The following is a description of a gene set: Human Gene Set: GSE11057_NAIVE_VS_CENT_MEMORY_CD4_TCELL_UP Genes up-regulated in comparison of naive T cells versus central memory T cells. Microarray deconvolution is a technique for quantifying the relative abundance of constituent cells in a mixture based on that mixture's microarray signature and the signatures of the purified constituents. It has been applied to yeast and other systems but not to blood samples. Here we test the ability of this technique to determine the fractions of subsets of memory T cells in peripheral blood mononuclear cell (PBMC) samples. studied in species Homo sapiens from publication Abbas AR, Wolslegel K, Seshasayee D, Modrusan Z, Clark HF (PMID 19568420), and this is the list of marker genes: ANKRD36BP2, CFAP418, NID1, SLC2A11, CHMP7, GPR160, MANSC1, CCR7 (C-C motif chemokine receptor 7), ZFTRAF1, CD248, SDR39U1, SOX5, APBB1, GAL3ST4, CIAPIN1, UBE2E2, SEC62, PIK3IP1, SREBF1, PLA2G12A, CWC22, MYB, SNX9 (NCBI Gene Id 51429), PLLP, ARMCX2, RAPGEF6, ALG10B, ETFBKMT, SLC25A37, SIAH1, PITPNM2, HEMGN, BNIP3, SLC11A2, EDAR, IL6ST (NCBI Gene Id 3572), NAA16, AMN1, CENPV, DCHS2, CEP41, PLAG1, ASIC1, EEA1, SFXN4, HOOK1, TOM1L2, ZNF563, GUCA1B, SYT9-AS1, LRRN3, HSBP1L1, TBC1D32, ENGASE, SULT1B1, ITGA6 (NCBI Gene Id 3655), SFMBT2, MIR101-1, FMO6P, PDCD4-AS1, DACT1, CSNK1G2-AS1, BBC3, OCRL, TECTB, CLCN5, SNHG32, TPCN1, SLC25A25-AS1, PADI4, MAN1C1, MESP2, OBSCN-AS1, LRRC52, RNF227, MAML2, GP5, PRRT1, NEURL4, CERS6, PDK1, THAP2, BNIP3L, COBLL1, TMEM272, ASB9, SMPD1, SNPH, ZNF436-AS1, CNKSR2, PHGDH, EFNA1, NPAS2, MALL, NUCB2, APBA2, CHST2, ZNF879, MEST, LEF1-AS1, SCML1, COL5A2, CHML, PCED1B, BEND5, ADAMTS12, VPS52, NOG, LINC01550, PRKD3, MPP1, RIN1, STK17A, GSAP (gamma-secretase activating protein), SATB1, RFLNB, GIMAP1, GP2, TMEM198B, TUG1, SAT2, MLXIP, LGR5, DEPDC7, CD55, IGF1R, AIF1, PXYLP1 (NCBI Gene Id 92370), PTPRK, DNHD1, SGK2, PDE7A, SERTM1, ADGRF3, MATN1-AS1, CAMK4, TTC28, MPP7, ZNF853, CEP70, CDIP1, TSPAN3, ASCL3, ZNF496, VNN2, STK26, KLF3-AS1, TGFBR2, SMOC2, RETREG1, CRLF3, USP44, PRXL2A, SERTAD2, NPM3, KLHL13 (NCBI Gene Id 90293), KAT2A, NBEA, TARBP1, RIN3, ZBTB18 (NCBI Gene Id 10472), SCARB1, LINC00582, C5orf58, NUDT17, PJVK, CFAP68, PSMB5, NSMF, ABLIM1, B3GAT1-DT, TMEM263, SCAI, AK5 (NCBI Gene Id 26289), ZSCAN12, ZNF506, ENSG00000274253, DDR1, ATP6V0A1, REG4, IQCF3 (IQ motif containing F3), MMP24, PRKCQ-AS1, AEBP1, CRTAM, HSF2, NDC1, ME3, RNF175, RIPOR2, ATM, KRT73, TAF4B, PKIG (cAMP-dependent protein kinase inhibitor gamma), NET1, LINC02175